The following is a description of a gene set: Mouse Gene Set: GOBP_POSITIVE_REGULATION_OF_MEMBRANE_DEPOLARIZATION studied in species Mus musculus Any process that activates or increases the frequency, rate or extent of membrane depolarization., and this is the list of marker genes: Cacna1d, Creb1, Cacna1c, Kdr, Ank3 (NCBI Gene Id 73013), Dcn, Myoc, Rack1, Mllt11, Alox12, Adcy10, Trpm4, P2rx7, Parp1, Oga, Tspo, Cck